The following is a description of a gene set: studied in species Mus musculus Mouse Gene Set: REACTOME_N_GLYCAN_ANTENNAE_ELONGATION N-Glycan antennae elongation, and this is the list of marker genes: B4galt4, St3gal4, Mgat4c, B4galt2, St8sia6, B4galt6, St6gal1, Mgat5, Mgat4a, B4galt3, Mgat4b, St8sia3, B4galt1, St8sia2, B4galt5